The following is a description of a gene set: The attachment of a cell, either to another cell or to an underlying substrate such as the extracellular matrix, via cell adhesion molecules that contributes to the shaping of the heart. species: Mus musculus Mouse Gene Set: GOBP_CELL_ADHESION_INVOLVED_IN_HEART_MORPHOGENESIS, and this is the list of marker genes: Acvr1, Rbpj, Tgfb2, Flrt2, Tgfbr2, Rac1, Gata5, Notch1, Cplane2